The following is a description of a gene set: part of: Caspase activation via Death Receptors in the presence of ligand This event has been computationally inferred from an event that has been demonstrated in another species.<p>The inference is based on the homology mapping from PANTHER. Briefly, reactions for which all involved PhysicalEntities (in input, output and catalyst) have a mapped orthologue/paralogue (for complexes at least 75% of components must have a mapping) are inferred to the other species. studied in species Mus musculus electronically inferred by orthology from the curated human pathway Reactome Pathway: Dimerization of procaspase-8, and this is the list of marker genes: Fas, Fasl, Casp8, Tradd, Fadd